The following is a description of a gene set: Human Gene Set: KEGG_MEDICUS_VARIANT_LMO2_REARRANGEMENT_TO_TRANSCRIPTIONAL_REPRESSION studied in species Homo sapiens LMO2-rearrangement to transcriptional repression. Pathway ID: N00122. Pathway type: Variant. Pathway class: nt06240 Transcription. Pathway Definition from KEGG: (LMO2*+LDB1) == (LYL1+TCF3) =| PTCRA, and this is the list of marker genes: PTCRA, LDB1, TCF3, LMO2, LYL1